Given this list of marker genes CXCL12, EFHD2, PCSK6, CELSR2, NAB1, EPHB4, ARHGDIA, CORO1B, COL9A2, PLGLB1, ATP2B4, MTSS2, ACBD4, here is a description of the gene set: from publication Chen Y, Wang X (PMID 31504780) Human Gene Set: MIR6889_5P Genes predicted to be targets of miRBase v22 microRNA hsa-miR-6889-5p in miRDB v6.0 with MirTarget v4 prediction scores > 80 (high confidence targets). species: Homo sapiens